Given this list of marker genes Wnt2, Fzd6, Pitx3, Wnt5a, Wnt3a, Wnt1, Ryk (NCBI Gene Id 20187), Fzd3, here is a description of the gene set: The multiplication or reproduction of cells, resulting in the expansion of a cell population in the midbrain. Mouse Gene Set: GOBP_CELL_PROLIFERATION_IN_MIDBRAIN species: Mus musculus